The following is a description of a gene set: Human Gene Set: GSE27434_WT_VS_DNMT1_KO_TREG_UP Genes up-regulated in T reg: wildtype versus DNMT1 knockout. studied in species Homo sapiens We investigated the role of DNMT1 in immune homeostasis by generating mice lacking DNMT1 in Foxp3+ T-regulatory (Treg) cells. These mice showed decreased peripheral Foxp3+ Tregs, complete loss of Foxp3+ Treg suppressive functions in vitro and in vivo, and died from autoimmunity by 3-4 weeks unless they received perinatal transfer of wild-type Tregs that prolonged their survival. Methylation of CpG-sites in the TSDR region of Foxp3 was unaffected by DNMT1 deletion, but microarray revealed more >500 proinflammatory and other genes were upregulated in DNMT1-/- Tregs. CD4-Cre-mediated DNMT1 deletion showed inability of conventional T cells to convert to Foxp3+ Treg under appropriate polarizing conditions. Hence, DNMT1 is absolutely necessary for maintenance of the gene program required for normal Treg development and function. from publication Wang L, Liu Y, Beier UH, Han R, Bhatti TR, Akimova T, Hancock WW (PMID 23444399), and this is the list of marker genes: DDX39B, CYBC1, NAXE, ENO1, CEP89, RING1, NAA38, PNKP, MBD3, CD99, CDC37, JOSD2, RPL34, MAN2B1, TMEM179B, AKAP1, ATP6V0A2, SELENOH, ZNF276, SCEL, JMJD8, PPFIA4, PPIB, SLC2A4, PLEKHO1, LMF1, YIPF3, SDC3, DDX27, B3GALT4, INTS3, EIF3K, ATP6V0E1, SMDT1, SHE, KRT6A, HFE, UBE4B, SH2D1B, COL4A4, RPS6KB2, YIF1A, CDT1, HIKESHI, NR2C2AP, SDHC, BAK1, TRAPPC14, SEMA4A, LRP10, CAPNS1, PRPF31, SLC50A1, ATP5MG, ALDOAP2 (ALDOA pseudogene 2), CHORDC1, ANKZF1, ABCC5, RBM42, GRN, MRPS12, ZFYVE19, ACVRL1, SEC24C, PTOV1, CRISP2, GUK1, ECH1, RAD1, ARL10, MRPL44, UQCRC1, EYA4, PRKCSH, FKBP8, SAMM50, TYMP, DAP, NME6, RAD50, PSMD3, SLC6A13, LYPLA2, SEC61A1, CTSG, ARHGAP45, ADPRM (NCBI Gene Id 56985), RAB4A, KCNJ9, MXD4, RGL2, TXNIP, ANAPC11, TPI1, MFNG, XRCC1, DYNLL1, SESN1, PTCD2, TM7SF2, SNRPB, BMP10, MKNK2, RCVRN, GNAS, STX18, PSMB6, FGF12, CLN6, NDUFS3, TMEM70, CSK (C-terminal Src kinase), TFIP11, UBALD2, SYT17, ERP29, FLT1, MFSD5, ZNF808, NUBP1 (NCBI Gene Id 4682), RBCK1, NELFE, PRKACA, COL13A1, CASP9, COTL1, GTF3C1, GLI1, CDK4, OGDH, C1QB, PPP1R21, ESRRA, HSF1, PROM1, FRAT1, PRKCD, SLC38A10, ETHE1, RSRP1, RPS23, SART3, SAP30, HRAS, BCAT2, PDZK1, FASTK, SLC35A1, ADAM28, PAM, FES, RPL28, SEC61B, SCNM1, MBD4, PAFAH1B3, PKIG, RPS5, SLC39A3, CTSA, SPSB2 (splA/ryanodine receptor domain and SOCS box containing 2), DAD1, IBSP, GOLGA3, KCNK1, EFNA1 (ephrin A1), RNF26, RERE, ZNF574, TMEM259, REEP5, TLE5, CLTA, CTSW, CDCA7L, RPP25L, ING4, PCK2, DFFA, CIAO1, FLCN, FAF1, SYNJ2BP, CSNK1G2, ISYNA1, SRP9, NBR1, XRN1, DCTN3, DLGAP5, AMMECR1L, USP29, CTSE, USP5, RPL19, NCBP2AS2, VIPR2, RBL1, LMAN2, TCAP